The following is a description of a gene set: Reduced strength of the axial musculature (i.e., of the muscles of the head and neck, spine, and ribs). Human Gene Set: HP_AXIAL_MUSCLE_WEAKNESS species: Homo sapiens Axial muscle weakness, and this is the list of marker genes: RRM1, KLHL40, GMPPB, MEGF10, COL6A2, ACTA1, MYBPC1, TRIP4, SELENON, MT-TL1, TPM2 (NCBI Gene Id 7169), SNUPN, DES, FKRP, CFL2, CRYAB, MYH7, COL6A3, LAMB2, BIN1 (NCBI Gene Id 274), SCN4A, MUSK, DOK7, LMNA, LMOD3, CNBP, BICD2, TTN, RNASEH1, MB, COL13A1, HMGCR, RYR1, COL6A1, MYL1, UNC45B, MYMX, COLQ, NAA80, NEB, BAG3, KLHL41, CACNA1S, MT-TN, PABPN1, COL12A1, POMT2, MT-TL2, HNRNPA2B1, POMT1, LARGE1, SPEG, TBCK